The following is a description of a gene set: species: Homo sapiens Any process that activates or increases the frequency, rate or extent of epidermis development. Human Gene Set: GOBP_POSITIVE_REGULATION_OF_EPIDERMIS_DEVELOPMENT, and this is the list of marker genes: KDF1, ELAPOR2, CYP27B1, ETV4, NME2, TRIM16, PPARD, SULT2B1, PKP1, FGF2, KRT10, OVOL2, BMP4, ALOX15B, ZBED2, TMEM79, IL20, PTCH2, MIR125B1, PTCH1, SFN, PLAAT4, KRT2 (keratin 2), NUMA1, MACROH2A1, NOTCH1, SPRR5, SFRP4, MACROH2A2, MED1, ATOH1, PRKCH, VDR, FOXC1, NCOA3